Given this list of marker genes TGM2, LIMS1, ITGA9, PFN1, MAPK8, KIF17, CACNB4, HDAC5, BTRC, ITGB3, WASF3, NPHP4, SH3GL2, PIP5K1C, NSF, SPEN (NCBI Gene Id 348488), CA9, NEBL, TEAD1, SEMA4C, GRIP2, NRG1, MAML1, HDAC7, ATN1, FLNB, CDC42BPA, here is a description of the gene set: from publication Sakai Y, Honda M, Fujinaga H, Tatsumi I, Mizukoshi E, Nakamoto Y, Kaneko S (PMID 19074895) species: Homo sapiens Human Gene Set: SAKAI_TUMOR_INFILTRATING_MONOCYTES_UP Hepatocellular carcinoma (HCC) is frequently associated with infiltrating mononuclear inflammatory cells. We performed laser capture microdissection of HCC-infiltrating and noncancerous liver-infiltrating mononuclear inflammatory cells in patients with chronic hepatitis C (CH-C) and examined gene expression profiles. HCC-infiltrating mononuclear inflammatory cells had an expression profile distinct from noncancerous liver-infiltrating mononuclear inflammatory cells; they differed with regard to genes involved in biological processes, such as antigen presentation, ubiquitin-proteasomal proteolysis, and responses to hypoxia and oxidative stress. Immunohistochemical analysis and gene expression databases suggested that the up-regulated genes involved macrophages and Th1 and Th2 CD4 cells. We next examined the gene expression profile of peripheral blood mononuclear cells (PBMC) obtained from CH-C patients with or without HCC. The expression profiles of PBMCs from patients with HCC differed significantly from those of patients without HCC (P < 0.0005). Many of the up-regulated genes in HCC-infiltrating mononuclear inflammatory cells were also differentially expressed by PBMCs of HCC patients. Analysis of the commonly up-regulated or down-regulated genes in HCC-infiltrating mononuclear inflammatory cells and PBMCs of HCC patients showed networks of nucleophosmin, SMAD3, and proliferating cell nuclear antigen that are involved with redox status, the cell cycle, and the proteasome system, along with immunologic genes, suggesting regulation of anticancer immunity. Thus, exploring the gene expression profile of PBMCs may be a surrogate approach for the assessment of local HCC-infiltrating mononuclear inflammatory cells. Selected genes up-regulated in inflammatory monocytes infiltrating hepatocellular carcinoma (HCC).